The following is a description of a gene set: Mouse Gene Set: DESCARTES_ORGANOGENESIS_EXCITATORY_NEURONS studied in species Mus musculus Mouse Organogenesis Cell Atlas (MOCA) DE_gene_main_cluster.csv, fold.change>=1.5, qval<0.05, pval<0.05 from publication Cao J, Spielmann M, Qiu X, Huang X, Ibrahim DM, Hill AJ, Zhang F, Mundlos S, Christiansen L, Steemers FJ, Trapnell C, Shendure J (PMID 30787437), and this is the list of marker genes: Gng4, Syt3, Gm28905, Pla2g4e, Rtbdn, Ssh3, Rap1gap, Hcrtr2, Dbh, Gm15624, Car10, Ntng1, D130004A15Rik, Bean1 (brain expressed, associated with Nedd4, 1), Acap3, Olah, Gm29514, Hs3st4, Vwc2l, Kndc1, Prrt1, Gm12371, Krt222, A230006K03Rik, Tmem63c, 3110080E11Rik, Sctr, Tafa1, Syt4, Gm39244, Zcchc12 (NCBI Gene Id 72693), Zbtb8b, Syngr3, 4930551E15Rik, Fgf11, Pnck, Ncam2, 4930567K12Rik, Lime1 (NCBI Gene Id 72699, Lck interacting transmembrane adaptor 1), Tac1, Gm16083, Rab9b, Gm9831, Ephx4, Gm16894